The following is a description of a gene set: Enables the transfer of a solute or solutes from one side of a membrane to the other according to the reaction: amino acid(out) + Na+(out) = amino acid(in) + Na+(in). studied in species Mus musculus Mouse Gene Set: GOMF_AMINO_ACID_SODIUM_SYMPORTER_ACTIVITY, and this is the list of marker genes: Slc38a4, Slc6a20a, Slc1a7, Slc1a1, Slc6a9, Slc6a14, Slc6a12, Slc38a7, Slc38a3, Slc1a3, Slc6a11, Slc6a5, Slc6a1, Slc6a6 (solute carrier family 6 (neurotransmitter transporter, taurine), member 6), Slc1a2, Slc6a20b, Slc6a13, Slc6a15, Slc1a6, Slc6a18, Slc38a1, Slc38a2, Slc6a7, Slc6a8